Given this list of marker genes SPRR3, LCN2, PRSS22, SLPI, SPRR1B, MAL2, KRT6B, ANXA1, S100A8, MALL, KRT13, MUC4, DSC2, CEACAM6, SULT2B1, KRT6A, CLIC3, CRABP2, TSPAN1, S100A7, SERPINB4 (NCBI Gene Id 6318, serpin family B member 4), PI3, GPRC5A, AQP3, S100P, WFDC2, CXCL17, SPRR2D, SPRR2A, KRT17, KRT16, AGR2, C15orf48, IL1RN (interleukin 1 receptor antagonist), KRT7, IGFBP3 (NCBI Gene Id 3486), CEACAM5, SAA1, CLDN7, PSCA, TACSTD2 (tumor associated calcium signal transducer 2), LY6D, FABP5, LYPD3, SERPINB1, PDZK1IP1, CLDN4, SERPINB3, ELF3, S100A9, here is a description of the gene set: species: Homo sapiens Genes upregulated in subsets of cells of a given type within various tumors Human Gene Set: GAVISH_3CA_MALIGNANT_METAPROGRAM_19_EPITHELIAL_SENESCENCE In this study, an extensive analysis was conducted to define meta-programs (MPs) capturing intra-tumor heterogeneity across a spectrum of tumor types. The approach utilized non-negative matrix factorization (NMF) to analyze each cell type separately within individual tumor samples. This involved the analysis of malignant cells, macrophages, fibroblasts, endothelial cells, epithelial cells, T-cells, and B-cells. NMF was executed with varying parameter values (K=4, 5, 6, 7, 8, 9), thereby generating 39 programs for each cell type per sample. Each NMF program was summarized by the top genes based on NMF coefficients.\nRobust MPs were then delineated for each cell type using a set of stringent criteria, including recurrence within the same tumor, similarity to programs in other tumors, and non-redundancy within a tumor. Subsequently, these robust NMF programs were clustered (per cell type) based on Jaccard similarity, leading to the identification of MPs associated with each cell type.\nTo enhance the quality of the MPs, a refinement steps were undertaken, involving the removal of MPs suspected of reflecting low-quality data (with an overrepresentation of ribosomal proteins or mitochondrial-encoded genes), single-study inclusion, or similarity to miss-annotated cell types. from publication Gavish A, Tyler M, Greenwald AC, Hoefflin R, Simkin D, Tschernichovsky R, Galili Darnell N, Somech E, Barbolin C, Antman T, Kovarsky D, Barrett T, Gonzalez Castro LN, Halder D, Chanoch-Myers R, Laffy J, Mints M, Wider A, Tal R, Spitzer A, Hara T, Raitses-Gurevich M, Stossel C, Golan T, Tirosh A, Suvà ML, Puram SV, Tirosh I (PMID 37258682)